The following is a description of a gene set: studied in species Homo sapiens Human Gene Set: REACTOME_BASE_EXCISION_REPAIR Base Excision Repair, and this is the list of marker genes: H4C12, RFC5, H2AC20, H2BC17, H2AZ2, POLE, H4C14, ADPRS, H4C1, H4C6, LIG1, H2AC19, MUTYH, H2BC4, TINF2, APEX1, H2BC7, H2BC11, H4C16, RPA1, SMUG1, POLD4, PNKP, H2BC15, H2AC4, H4C5, NEIL3, H2AB1, H2BC12L, POLE4, TERF2IP, H2BC1, H2BC3, PARP1, H4C11, TERF1, NTHL1, ACD, H4C15, MBD4, NEIL1, RFC1, H2BC26, H2AC7, PARG, RFC3, RFC4, H2AC18, H2BC6, POLD3, RPA2, UNG, H2AX (H2A.X variant histone), H2BC14 (NCBI Gene Id 8342), H4C4, H4C2 (NCBI Gene Id 8366), H2BC8, H2BC10, POLE3, OGG1, H3-4, POLD1, H2AC8, PARP2 (NCBI Gene Id 10038), RFC2, LIG3, XRCC1, H2BC5, PCNA, FEN1, H4C9, POT1, H2AC14, TDG, POLB (DNA polymerase beta), H2BC12, H2AC6, H2BC13, H4C3, RPA3, H2AJ, H2BC21, H4C8, H4C13 (NCBI Gene Id 8368), TERF2, NEIL2, H2BC9, MPG, POLE2, POLD2